Given this list of marker genes FLI1, THPO, HPS6, IKZF5, RUNX1, P2RY12, AP3B1, RASGRP2, TPM4, ITGA2B, HPS5, ACTN1, ITGB3, GP1BA, SH2B3, MYH9, EPHB2, CALR, here is a description of the gene set: Abnormal platelet response to ADP as manifested by reduced or lacking aggregation of platelets upon addition of ADP. species: Homo sapiens Human Gene Set: HP_IMPAIRED_ADP_INDUCED_PLATELET_AGGREGATION Impaired ADP-induced platelet aggregation